Given this list of marker genes Gp1bb, Gp9, Gp1ba, Gp5, Flna, here is a description of the gene set: Mouse Gene Set: GOCC_GLYCOPROTEIN_IB_IX_V_COMPLEX studied in species Mus musculus A transmembrane signaling receptor complex found exclusively on platelets. Involved in haemostasis and thrombosis where it aids blood coagulation.